Given this list of marker genes IDE, TXNDC16, NGLY1, PPP2R5D (protein phosphatase 2 regulatory subunit B'delta), SYNGR3, IL2, TNFSF9 (NCBI Gene Id 8744), DCTPP1, GNG10, PALS2, PPP2R3A, TTL, RAB19, ACTR1A, NAA16, IL3RA, CENPV, TRABD, REEP3, MRPS18A, MEGF9, ANXA4, SERPINE3, TUBGCP2, AIFM2, H4C14, ANAPC4, REEP2, TXNL1, MRPS35, GLOD4, GPR89B, MYADM, LRRFIP2, CWC15, MIR367, RAB27A, RNF39 (NCBI Gene Id 80352), B9D2, OTULIN, TRIM37 (tripartite motif containing 37), NACC1, HYLS1, DYNLL2, TMEM14C, SOAT1, TYRO3, SEC24D, DSTN, IFT27, MTA2, TXN, MCM4, PMAIP1, CDKN2A, TAPT1, CD200, PRKAR2A, PDAP1, PMVK, MRPS24, ISCA2, DGKH, MRPL1, BBC3, SNX25, PSMA2, CARF, FBH1, SF3A3, FLII, NEMP1, UQCRQ, CENPS, RWDD2B, BOLA3, SSX2IP, TCEA1, SELP, B4GALT5, BAG3, CDC27, RPN1, UFM1, MANBA, NEDD1, RELL1, ENDOU, HAVCR2, PDCD1, SEMA6B, MRPL36, STOML2, C1QTNF12, RCC1, ZIK1, ASNSD1, RPUSD3, NUSAP1, GMNN, HTATIP2, NUP155, HSF4, HOXA13, NUP210L, ADARB1, COQ7, DNAJC12, ELOA, SSH1, KLHL5, KDM4A, EID2B (NCBI Gene Id 126272), ZCCHC9 (zinc finger CCHC-type containing 9), NR4A2, ATP5PB, HOXA9, LYPLA1, PSMC3IP, TJP2, RBM44, FUT4, PSTPIP1, DNM1L (dynamin 1 like), NEK4, PON2 (NCBI Gene Id 5445), H1-10, GSR, THAP6, BRINP1, CTSW, UQCR10, CCDC25, GZF1, DDX19A, FBXO33, DNAJB12, CERS2, SNX1, SLC31A1 (NCBI Gene Id 1317), IFNGR1, B4GALNT4, FANCG, SH2D1A (NCBI Gene Id 4068), GHITM, WDR62, NR2F6, ERBB3, FANCM, CRYZ, FUNDC2, GNAS, INSL6, INPP5K, TMA7, DNMT1, NELFCD, VGF, MTMR1, HDAC6, PDIA6, FHL2 (four and a half LIM domains 2), TIMM44, DYRK1B, IPO11, PLPP2, ZCCHC18, PMPCB, CNIH4, PCYT1B, PLEK, MAP3K5, DCTN2, MRPS18C, here is a description of the gene set: from publication Fulcher JA, Hashimi ST, Levroney EL, Pang M, Gurney KB, Baum LG, Lee B (PMID 16785517) Human monocyte derived dendritic cells matured via galectin-1 or LPS. species: Homo sapiens Genes down-regulated in monocyte-derived dendritic cells: control versus LPS. Human Gene Set: GSE4984_UNTREATED_VS_LPS_TREATED_DC_DN